The following is a description of a gene set: Human Gene Set: GOMF_ANNEALING_ACTIVITY An activity that facilitates the formation of a complementary double-stranded polynucleotide molecule. studied in species Homo sapiens, and this is the list of marker genes: EIF4H, RECQL, TP53, BLM (NCBI Gene Id 641), ZRANB3, SMARCA1, SMARCAL1, FXR1, RECQL4, EIF4B, DDX3X, FMR1, RAD54L